The following is a description of a gene set: Genes down-regulated in FL5.12 cells (pro-B lymphocyte) in response to methotrexate. DNA microarrays are powerful tools for the analysis of gene expression on a genomic scale. The importance of individual regulatory events for the process under study can however not be deduced unequivocally without additional experiments. We devised a strategy to identify central regulators of cancer drug responses by combining the results of microarray experiments with efficient methods for phenotypic testing of candidate genes. We exposed murine FL5.12 pro-B cells to cisplatin, camptothecin, methotrexate or paclitaxel, respectively and analysed the patterns of gene expression with cDNA microarrays. Drug-specific regulatory events as well as intersections between different apoptotic pathways, including previously studied responses to staurosporine and interleukin-3 (IL-3) deprivation, were identified. Genes shared by at least three pathways were chosen for further analysis. Ectopic expression of three such genes, TEAP, GP49B, and Lipin1 was found to have an anti-proliferative effect on pro-B cells. Interestingly, we identified hemoglobin alpha as a strong pro-apoptotic regulator. While hemoglobin-expressing cells were growing normally in the presence of IL-3, they displayed accelerated apoptosis with similar kinetics as Bax overexpressing cells upon IL-3 removal. The pro-apoptotic effect of hemoglobin was suppressed by Bcl-2 and was characterized by enhanced stimulation of caspase activity. Mouse Gene Set: BRACHAT_RESPONSE_TO_METHOTREXATE_DN studied in species Mus musculus from publication Brachat A, Pierrat B, Xynos A, Brecht K, Simonen M, Brüngger A, Heim J (PMID 12447701), and this is the list of marker genes: Fkbp3, Ppia, Ndufv3, Gapdh, Stat5a (signal transducer and activator of transcription 5A), Pdk3, Eno1b, Gpi1, Ifitm3, Hmgcs1, Emilin2 (elastin microfibril interfacer 2), Slc25a1, Bnip3l, Mt1, Aldoa, Sash3, Ifitm2, Mia2, Bcl2, Higd1a, Ostf1, Eno3 (NCBI Gene Id 13808), Hikeshi, Coro7, Ak4, Anxa4